Given this list of marker genes GATA1, CA2, ERCC6L2, FANCL, ADH5, CLCN7, THPO, CTC1, TLR8, TINF2 (TERF1 interacting nuclear factor 2), PRF1, RTEL1, FLI1, SLC30A7 (NCBI Gene Id 148867), NHP2, MYSM1, CASP10, WDR19 (NCBI Gene Id 80203), ZCCHC8, DNAJC21, CLPB, MDM4, SF3B1, TET2, BRCA2 (NCBI Gene Id 82716), RPS14, STN1, TERT, BRIP1, SRP72, TBXAS1, DDX41, GNAS, SBDS, SMARCAL1, IFNG, PGM3, DCLRE1B, DKC1, WRAP53 (WD repeat containing antisense to TP53), GATA2, PARN, ACD, TYMS, NPM1, GALE, PDCD1, MAD2L2, VPS33A, TERC, FAS, LBR, ERCC4, TGFB1, FANCI (NCBI Gene Id 751608), RPA1, FANCF, RAD51, FANCD2, FASLG, USB1, UBE2T, NBN, NOP10, FANCC, EFL1, SAMD9, RPL26, IVD, ADA2, here is a description of the gene set: Human Gene Set: HP_BONE_MARROW_HYPOCELLULARITY species: Homo sapiens Bone marrow hypocellularity A reduced number of hematopoietic cells present in the bone marrow relative to marrow fat.